The following is a description of a gene set: ESR-mediated signaling species: Homo sapiens Human Gene Set: REACTOME_ESR_MEDIATED_SIGNALING, and this is the list of marker genes: GPAM, POLR2C, IGF1R, H3C15, H2AX, CXXC5, RAD21, H2AC8, TFF3, JUND, TGFA, H2BC12L, POLR2K, PTGES3, STAG1, FOS, XPO1, H4C16, AGO2, MYB, ERBB4, SRF, H4C1, PIK3CA, PPP5C, CCNT1, H4C14, POLR2G, SHC1, H2AC14, HBEGF, H3C4, HSP90AA1, H2BC7, H2BC4, TNRC6C, FOSB, H2BC5, H3C1, CHD1, AKT3, STAG2, AREG, H4C3, FOXO3, GNG13, S1PR3, H2AZ2, H2AC19, ZDHHC7, CITED1 (Cbp/p300 interacting transactivator with Glu/Asp rich carboxy-terminal domain 1), CCND1, H4C5, MED1, GNB4, MMP7, GNB2, CREBBP, GNG4, H4C15, MYC (NCBI Gene Id 731404), POLR2J, H2AJ, UHMK1, EGFR, MAPK1, FKBP4, GNG3, H2BC11 (H2B clustered histone 11), PRMT1, NRIP1, TNRC6B (trinucleotide repeat containing adaptor 6B), NOS3, AGO4, H2AC7, H3C13, H2BC1, EREG, H2BC8, CDK9, GNG8, EGF, JUN, TFF1, ZDHHC21, HSPB1, H3C3, SMC1A, SRC, NR5A2, YY1, POLR2D, AGO3, TBP, H2AC18, FOXA1, NRAS, CALM1, H4C9, PGR, CARM1, H4C11, FKBP5, POLR2A (NCBI Gene Id 5430), CAV1, AKT2, H2AB1, NCOA2, MAPK3, H2BC6, POU2F1, CXCL12, MMP3 (matrix metallopeptidase 3), GNG7, DDX5, TLE3, H4C2, USF2, GTF2A2, PTK2, GTF2A1, ATF2, PIK3R2, GNGT1, EP300 (NCBI Gene Id 2033), GNG5, NCOA1, H2BC14, GNGT2, HDAC1, H2AC20, H3C8, MMP2, H4C4, H2BC21, ZNF217, H2BC13, STRN (striatin), KAT2B, KAT5 (NCBI Gene Id 10524), GNB5, MMP9, H3-3A, H2BC10, GNG10, GNG2, PDPK1 (NCBI Gene Id 5170), EBAG9, KRAS, PIK3R3, MOV10 (Mov10 RNA helicase), H4C12, GNB3, GNG12, H2AC4, BTC, H2BC9, GNB1, SP1, H4C6, SMC3, POLR2L, GREB1, EPGN, POLR2H, POLR2I, H3C2, ELK1, H4C8, H2BC17, SPHK1, CAV2, AKT1, GTF2F2, TNRC6A, H3-3B, H2BC3, RUNX1, POLR2F, H2BC26, H3C6, PPID, KCTD6, H3C11, GATA3, CDKN1B, CTSD, GNAI3, GTF2F1, USF1, GNAI2, KDM4B, NCOA3 (nuclear receptor coactivator 3), PIK3R1, POLR2E, BCL2, H2BC12, H3C7 (NCBI Gene Id 8968, H3 clustered histone 7), HRAS, H2AC6, POLR2B, ESR1 (NCBI Gene Id 2099), GNG11, CBFB, KDM1A, AGO1, H3C12, KANK1, H3C10, KPNA2, CREB1 (NCBI Gene Id 1385), ESR2, HSP90AB1, AXIN1, H3C14 (H3 clustered histone 14), GNAI1, GNAT3, H2BC15, PRKCZ, H4C13